The following is a description of a gene set: Mouse Gene Set: TERF1_TARGET_GENES from publication Yevshin I, Sharipov R, Kolmykov S, Kondrakhin Y, Kolpakov F (PMID 30445619) Genes containing one or more binding sites for (Terf1) in their promoter regions (TSS -1000,+100 bp) as identified by GTRD version 20.06 ChIP-seq harmonization. species: Mus musculus, and this is the list of marker genes: Denr, Wdr77, Bptf, H4c8, Mob1a, Cdca7, Dnajc11 (NCBI Gene Id 230935), Arid5b, Rap1gap, Nol9, Mdh2, Puf60, Snord1c, Ciapin1, Rab11a, Tti2, Atp5mc2, Rbm39, Cdk12, Glra1, Iqsec1, Rapgef1, Cacng2, Fbxo31, Tagln, Snord13, Ssbp1, Ostc, Gdi2, Zcchc14, Ccdc88a, Gm25541, Styxl1, Gm17484, Mms22l, Mir5133, Top1mt, Sh3glb1 (NCBI Gene Id 99782), Coq9, Rbm26, Kdm3b, Ddhd2, Mapk14, Prepl, Camkmt, Qrich1, Scrt1, Haspin, Micu2, Snora7a, C230035I16Rik, Baz2b (NCBI Gene Id 51934), Nptn, Glce, Aco2, Tubgcp5, Aloxe3, Dffa, Sucla2, Scamp5, Acbd4, B230219D22Rik, Zzz3, Hspa4, Ttc14, Fcgr3, Marchf7, Abi1, Pfkfb2, Rps3a1, Rnf187, Phf5a, Rraga, Mcts2, Man2a2, Rpl32, Vps36, Nipsnap2, 3110083C13Rik, Arf3 (ADP-ribosylation factor 3), Pkn3, Mad1l1, Nsun3, Taf6, Disp3, Rpl26, Rps19, Tas1r1, Cnpy4, Nudt1, Golm2, Ankfy1, Snhg16, Adprs, Ercc6l2, Gm13421, Prmt5, Gm16170, Akap11, Tia1, Srrm3 (serine/arginine repetitive matrix 3), Cep164, Atp5pb